The following is a description of a gene set: studied in species Homo sapiens Genes having at least one occurrence of the motif NWGGAAANWN in the regions spanning 4 kb centered on their transcription starting sites. This matches the NFAT, NFATC transcription factor binding site V$NFAT_Q4_01 (v7.4 TRANSFAC). Human Gene Set: NFAT_Q4_01, and this is the list of marker genes: SH3RF1, SLA, RABL6 (RAB, member RAS oncogene family like 6), HOXB4, TCTA, PRPF38B, SHOX2, PLPPR1, NFIL3, TOB2, PSMA1, IL1RAPL1, IGFBP5, MRPL30, TRPS1, GATA4, MAP4K4 (mitogen-activated protein kinase kinase kinase kinase 4), ORMDL3, FCRL2, SLC16A6, C1QL1, FLI1, GPC3, AKR1B1, VIT, SERPINB7, NR5A2, KIRREL3, PCDH17, HSPG2, TFDP2, FOXP1, OTUD7B, NREP, KLHL4, NEDD4L, IER3, TYR, HNRNPH3, PPM1K, TTLL6, ZIC4, FOXP2, ATP1B3, CHRDL1, MBNL2, ZNF710, MAPK4, STOML2, FOS, STC1, PTHLH, KCNQ5, ZNF675, MIER3, ZBTB2, WDR81 (WD repeat domain 81), ID3, TMEM108, SPAG17, RORC, KCNE2, HMGN3, LUZP1, ETV1, NKRF, ZNF800 (zinc finger protein 800), MAP2K3 (NCBI Gene Id 92079), NR4A2, HTR3B, BNC2, CTDSP1, NFAT5, IFT20, ARRDC3, CREB5, PCDH10, IGFBP3, OVOL2, CCDC91, SREK1, LIMS1, KCNJ8, SEMA3A, STAG1, SORBS3, JPT2, ECEL1, DHRS3, FXYD2, SLC5A3, DTX3, UBR5, PPAN (NCBI Gene Id 84997), POFUT1 (protein O-fucosyltransferase 1), CASK, PHKA1, NR4A3, E2F3, NRIP2, SOX5, PRDM1, NR3C2, CUEDC1, TPM3, RASGEF1A, GSTA4, TBX4, RNF220 (ring finger protein 220), PKP3, CTSK, STC2 (NCBI Gene Id 8614), PAK3, FDX1, DICER1, CAVIN1, RHOA, MAST2, PBX4, SYT4, ISYNA1, SLITRK3, SNX25 (sorting nexin 25), CNIH2, TJP2, RNF128, NDRG2, AUTS2, BHLHE40, ABI3 (ABI family member 3), NFKBID, LTC4S, GSN, GNGT2 (G protein subunit gamma transducin 2), FHL5, EOMES, BRINP3, GPR107, PAK1IP1, ZBTB10, DDX3X, ABRAXAS2, APOBEC2 (apolipoprotein B mRNA editing enzyme catalytic subunit 2), GTF2E1, PPM1D, EXT1, USP2, RAPGEF6, UBE2Z, SMPD3, PRRG4, CADM2, TRIM63, EXD2, IL2, HOXB2, ZNF503, OGT, ZMYND8, TIAM1, HOXD10, SLC6A5, LIMK2, IL13, MRPL45, STIP1, XPO1, MITF, SCRN3, GRK2, FGF14, PPP4R4, FEZF2, CYP2D6, AMOTL1, TMEM54, VN1R3, ORAI3, B4GALT5 (NCBI Gene Id 9334), NRN1L, MRGPRF, HOXA3, CCL5, PPP2R3A, EBF1, ZNF143, TAGAP, RND2, C12orf50, ARL6IP5, SOX3, BICDL1, UTP18, GFI1, PLAGL2, USP12, CCDC140, ANKRD28 (NCBI Gene Id 23243), CNTFR, ZFHX3, CD72 (NCBI Gene Id 971), FOXO4, EHBP1, IL4, PACSIN2, KLF5, GAS7, EPYC, KIRREL3-AS3, KLF13, SLITRK1, ZBTB5, TSHZ3, SOX9, KRT14, DEF6, ABLIM2, TRERF1, MDH1, PDZRN4, ZNF768, ST8SIA1, FLOT1, UXS1, KCNJ5 (potassium inwardly rectifying channel subfamily J member 5), TEAD1, SGCD, ANP32A, RGS3, MAN1A1, WFIKKN2, HS6ST3, MITD1, JARID2, TFAP4, RASGRP4, PROK2, PAX3, DPF2, PTGES, VAMP8, KIRREL2, RUSC1-AS1, ZHX2, KRT8P41, SLC4A2 (NCBI Gene Id 96677), PHF6, NOTUM, TNFAIP1, CALN1, SNAP25, KMT2C, ANP32E, PDE3B, ICAM1, ACER1 (NCBI Gene Id 378767), PHOX2B, VAX1, PITX2, SRPK2, HNRNPC, PLOD2, ELK3, SDCBP (syndecan binding protein), NDP, SCAMP1, PTPRZ1, MIR22HG